The following is a description of a gene set: studied in species Mus musculus Mouse Gene Set: MIR_1950 from publication Chen Y, Wang X (PMID 31504780) Genes predicted to be targets of miRBase v22 microRNA mmu_miR_1950 in miRDB v6.0 with MirTarget v4 prediction scores > 80 (high confidence targets)., and this is the list of marker genes: Sh2d4a, Klf4, Hps5, H2-T22, Rb1cc1, Sptlc2, Trem6l, Cacna1h, Cluh, Cdh1, Phip, Lemd3, Kctd9, Kif16b, H2az1, Dsg1b, Herpud1 (homocysteine-inducible, endoplasmic reticulum stress-inducible, ubiquitin-like domain member 1), Vps37b, Phyhip, Ttc8, Snapin, Fndc3b, Hspa12a, Ablim1, Srek1, Sln, Irak4, Sacm1l, Dbp, Mxi1, Wapl, Akr1c19, Ssbp2, Cacnb4, C1s1, Btaf1, Myo15a, Ptbp2, Ptchd4, Sugt1, Fbxl14, Slain2, Birc6, Bmpr2, Gcnt7, Sowahd, Tstd2, Slc24a2, Rnf214, Krtap9-22, Mbnl2, Slc35g2, Hepacam2 (HEPACAM family member 2), Zfp879, Puf60, Fubp1, Cxadr, Aak1, Tcf24, Fam210a, Rgs7, Adam10, Camk2g, C1ra, Mllt3, Tlk2, Avl9, Npm1, Plekhb2, Fut9, Dcx, Ddx4, Ugt8a, Zfp106, Arf6, Ip6k2, Ankrd44, Itpr1, Nras, Fgf5, Fstl1, Rad54l2, Mpv17l, Gpr35, Rnft1, Nfya (nuclear transcription factor-Y alpha), Socs5, Cntn5, Txlng, Satb1, Pla2g4f, Kirrel3, Dcdc2a, Tspan12, C1s2, Scfd1, Kdm2b, Rtn4, Arih2 (NCBI Gene Id 23807), Sohlh2, Smarcad1, Dr1 (NCBI Gene Id 67362), Ddx17, Bean1, Flrt2, Egflam, Ppat (NCBI Gene Id 97242), Zfp445, Map3k13, Neu1, Clstn2, Ppp6r3, Nmb, Cttnbp2nl